Given this list of marker genes Gm26148, Mir6400 (NCBI Gene Id 102466644), Tmem64, Gm11844, Gm11869, Decr1, Gm11870, Gm24317, Ripk2, Gm24978, A530072M11Rik, Gm23975 (predicted gene, 23975), Osgin2, Gm11848, Nbn, Gm11857, Gm11855, Gm11837, Gm11849, Gm11858, Gm11865, Gm11862, Gm11850, Calb1, Gm11864, Necab1, here is a description of the gene set: studied in species Mus musculus Mouse Gene Set: chr4A2